The following is a description of a gene set: Human Gene Set: GOMF_TOLL_LIKE_RECEPTOR_4_BINDING Binding to a Toll-like 4 protein, a pattern recognition receptor that binds bacterial lipopolysaccharide (LPS) to initiate an innate immune response. studied in species Homo sapiens, and this is the list of marker genes: DAB2IP, TIRAP, LY96, S100A8, S100A9